The following is a description of a gene set: species: Mus musculus Mouse Gene Set: GOBP_FATTY_ACID_TRANSMEMBRANE_TRANSPORT The process in which a fatty acid is transported across a membrane., and this is the list of marker genes: Akt2, Slc25a20, Abcd1, Thbs1, Cpt2, Cpt1b, Slc27a5, Abcd2, Abcc1, Slc2a1, Acsl1 (NCBI Gene Id 56355), Abcd3, Acsl6, Acsl5, Slc27a1, Irs2, Slc5a8, Cd36, Abcd4, Akt1